Given this list of marker genes Chrne (cholinergic receptor, nicotinic, epsilon polypeptide, NCBI Gene Id 11448), Chrna4, Chrnb2, here is a description of the gene set: This event has been computationally inferred from an event that has been demonstrated in another species.<p>The inference is based on the homology mapping from PANTHER. Briefly, reactions for which all involved PhysicalEntities (in input, output and catalyst) have a mapped orthologue/paralogue (for complexes at least 75% of components must have a mapping) are inferred to the other species. part of: Postsynaptic nicotinic acetylcholine receptors; Presynaptic nicotinic acetylcholine receptors studied in species Mus musculus Reactome Pathway: Highly sodium permeable postsynaptic acetylcholine nicotinic receptors electronically inferred by orthology from the curated human pathway